The following is a description of a gene set: Mouse Gene Set: GOBP_ACTIN_FILAMENT_ORGANIZATION studied in species Mus musculus A process that is carried out at the cellular level which results in the assembly, arrangement of constituent parts, or disassembly of cytoskeletal structures comprising actin filaments. Includes processes that control the spatial distribution of actin filaments, such as organizing filaments into meshworks, bundles, or other structures, as by cross-linking., and this is the list of marker genes: Myo1g, Micall2, Pfn3, Fhod3, Zeb2, Abl1, Dstn, Sdc4, Nphs1, Mtss1, Neb, Srf, Wasf3, Hcls1, Ccl21e, Capg, Nck2, Nckap1, Itgb1bp1, Tcap, Rhobtb1 (NCBI Gene Id 73196), Vill, Tmeff2, Actg1, Specc1l, Diaph2, Rock2, Rhov, Fam107a, Arpc1a, Arpc5l, Cobl, Sorbs1, C9orf72, Synpo2, Rhpn2, Washc5, Myh9, Cnn2, Myo1c, Trim27, Ttc8, Ccl21d, Coro2b, Kctd13, Rasa1 (NCBI Gene Id 218397), Flna, Ptger4, Arhgef18, Dpysl3, Fscn3, Fhdc1, Myo5c, Fchsd2, Lpar1, Dsg3, Bbs4, Wnt4, Nckap1l, Twf1, Cotl1, Rdx, Rhoa, Rac2, Ccl21b, Sptan1, Wmp, Carmil2, Whamm, Pick1, Ssh2, Cdc42ep2, Dlc1, Sh3kbp1, Capza1, Fmn2, Ttc17, Daam2, Ccl11, Phldb2 (pleckstrin homology like domain, family B, member 2), Wasf2, Ssh3, Enah, Tmsb15b2, Washc2 (WASH complex subunit 2), Rnd1, Gas2l1, Sorbs3, Cracd, Svil, Gba2, Ppp1r9a, Myadm, Src, Pak2, Ppm1f, Rhoh, Actr3, Cyfip2, Hip1r, Coro1b, Abi2, Myo19, Rhog, Washc4, Pecam1, Myo7a, Rhof, Brk1, Inf2, Shank3, Pacsin1, Tle6, Rac3, Espnl, Actr2, Tpm3-rs7, Dlg1, Wdr1 (WD repeat domain 1), Crhr2, Rhod, Tacr1, Myo6, Scin, Ccl24, Myl9, Cav3, Clrn1, Arhgap17, Arf1, Kank1, Cdc42ep5, Myo1f, Arhgef2, Aqp2, Elmo1, Tagln3, Cnn1 (NCBI Gene Id 12797), Kash5, Sh3pxd2b, Stmn1, Arhgef10, Eln, Naa80, Myo15a, Map3k1, Add1, Prkcq, F11r, Spag6l, Lmod1, Plekhg2, Fscn1, Trpv4, Xirp1, Fer, Carmil3, Mlst8, Cul3, Gm14137, Sptb, Pycard, Spatc1l, Ush1c, Marcksl1, Samd14, Tsc1, Met, Trf, Vasp, Pfn5, Ctnna2, Iqgap1, Tacstd2, Msrb1, Arf6, Myo7b, Kbtbd13, Ccl21f, S100a10, Zbed3, Rnh1, Plec, Gpr65, Dbnl (drebrin-like), Actn2, Nlrp5, Snx9, Synpo, Baiap2l1, Id1, Tmod2, Rnd3, Shroom3, Elmo3, Asap3, Pxn, Ccl26, Myo1h, Rac1, Coro6, Actn4, Inpp5k, Gdpd2, Myo1e, Ttn, Cfl2, Arhgap28, Esam, Sh3bp1, Tpm1, Cryaa, Bcar1, Epha1, Wasl, Cttn, Rgs4, Spire2, Cap2, Abl2, Acta1, Mtpn, Arhgap12, Rhpn1, Ap1ar, Tnfaip1, Was, Arhgef15 (Rho guanine nucleotide exchange factor 15), Capzb, Gmfg (glia maturation factor, gamma), Evl, Dnai3 (NCBI Gene Id 242253), Fat1, Tpm4, Nrp1, Bcl2, Lats1, Iqgap3, Gas7, Prkcd, Shroom2, Cdc42, Nlrp4f, Clec2i, Arpc3, Kptn, Kirrel1, Kank2, Pik3r1, Nf2, Plekhh2, Prkce, Arpin, Sh3d21, Pik3ca, Luzp1, Tjp1, Arfip1, Fam171a1, Csf3 (colony stimulating factor 3 (granulocyte)), Arrb1, Tenm1, Gas2l3, Cdc42ep3, Espn, Arhgap40, Tac1, Arpc1b, Rhou, Magel2, Bag4, Cfl1, Arhgap18, Fermt2, Pawr, Mkks, Tmsb10, Icam1, Tpm2, Twf2, Rflnb, Pdlim4, Pakap, Phactr1, Gas2, Nrap, Diaph1, Pls1, Arhgap25, Pdlim3, Pls3, Tpm3, Tgfbr1, Capn1, Kank4, Ezr, Tnnt2, Cnn3, Mir129-2, Ccdc88a, Cd2ap, Tmsb15l, Rhob (ras homolog family member B), Hsp90b1, Pik3r2, Pdxp, Arhgap6, Alms1, Clasp2, Cit, Khdc3, Fmn1, Pak1, Ppfia1, Cdc42ep1, Fscn2, Smad3, Nck1, Arhgap35, Prex1, Hax1, Add2, Fhod1, Arhgef10l, Casp4, Cdc42ep4, Pdlim1, Myo1a, Rnd2, Baiap2, Shank1, Washc1, Capza1b, Cx3cl1, Rufy3, Limk1, Sema5a, Tmod3, Ssh1, Prkn, Arpc4, Pcdh15, Tmod4 (NCBI Gene Id 50874), Xirp2, Nebl, Sirpa, Prkci, Fchsd1, Coro1a, Wnt11, Trpv3, Emp2, Ppm1e, Tesk1, Actc1 (actin, alpha, cardiac muscle 1), Lmod2, Ghrl, Mtor, Arap1, Ghsr, Serpinf2, Lima1, Washc3, Diaph3, S1pr1, Dbn1, Itgb5, Rictor, Hdac6, Mical3, Gja1, Pfn1, Baiap2l2, Frmd7, Shroom1, Grb2, Kank3, Pfn2 (NCBI Gene Id 18645), Limd2 (NCBI Gene Id 67803), Elmo2, Eps8, Avil, Rhobtb2, Mical1, Coro7, Myo1b, Rhoc, Ptk2b, Wipf3, Limch1, Braf, Aif1, 4930544G11Rik, Cyrib, Vil1, Aif1l, Wasf1, Prox1 (prospero homeobox 1), Swap70, Coro1c, Mical2, Arfgef1, Tmod1, Mad2l2, Rhoj, Spire1, Ang, Rhoq, Arfip2, Bin1, Abitram, Nox4, Iqgap2, Cap1, Clasp1, Tagln2, Flii, Tgfb3, Ccl21a (C-C motif chemokine ligand 21 (serine)), Arpc2, Gmfb, Apoa1, Slit2, Bloc1s6, Pof1b, Lcp1, Itgb1, Myo1d, Ermn, Carmil1, Tlr2, Cyfip1, Plek, Gsn, Rgcc, Myo5a, Alox15, Arhgef5, Cald1, F2rl1, Myo5b, Cgnl1, Marcks, Capza2, Dnm2, Capza3, Shroom4 (shroom family member 4), Spta1, Myh10 (myosin, heavy polypeptide 10, non-muscle), Hip1, Jmy, Gm28729, Ooep, Arpc5, Catip, Cyria, Pak3 (p21 (RAC1) activated kinase 3), Rapgef3, Zyx, Kiss1r, Sptbn1, Inppl1, Add3, Synpo2l, Cd47, Ccn2, Dmtn, Actn1, Gas2l2, Tmsb4x, Myoc, Lmod3, Ppargc1b, Shtn1, Msrb2, Ppp1r9b, Rflna